Given this list of marker genes ZNHIT1 (NCBI Gene Id 10467), YTHDF1, PRPF38A, SSBP3 (NCBI Gene Id 55126), IL4I1, CAPN8, SIPA1L2, PRPF40A, RIN2, ACVR1, MPP4, CCR8, PBDC1, RUFY3, ARL4A, GOLGA3, TREH, COX17, SLFN12, TMEM168, MRPS7, PAXBP1 (NCBI Gene Id 94104), CDK2AP1, RILPL2, TRAPPC5, EVC, RHBDF1, ABCF1, ATM, SAV1, COX18, SLC28A2, CRKL, RAB22A, CCL7, LY75, PIP4K2B, CCL13, ATF3, ITK, STXBP3, IFIH1, HLA-B, FSCN1, ZMYND11, RFK, FABP4, SOCS6, APOBEC1, PLGRKT (plasminogen receptor with a C-terminal lysine), CD86, SIX5, SFRP1, MBD2 (NCBI Gene Id 8932), WASHC2A, ODC1, HNRNPLL, RTP4, NT5C3A, PLSCR1, DUSP2, CD244, MMS22L, AKAP7, SFXN2, NUB1, GTPBP2, AFTPH, CEPT1, TNFSF9 (TNF superfamily member 9), RIPPLY3, AKR1A1, KPNA3, TOMM70, EVI2A, FRAT2, NMD3, TMEM54, KDM5C, CAMLG, MED1, FKBP7, BRDT, SLC25A20, RPS27, CCNJ, NUS1, CPSF2, CDKN2C, NAT1, ARID2, SPTLC2, HERC2, CPTP, RHOH, CTSG, UBE2R2, SLC6A12, SOCS7, NMNAT1, PADI3, LAD1, TBC1D13, GRIN1, CHRNA5, MRPS6 (mitochondrial ribosomal protein S6), CHST4, B4GALT4, ANKRD24, TMCO3 (transmembrane and coiled-coil domains 3), AP3D1, IQGAP3, HINFP, CCDC102A, TIMELESS, SERPINE1, MUSTN1, CDC42EP3, KDR, POLR1C, ISG20, UBE2D2, TMEM140, ZNF428, MTFP1, HHEX, NRROS, WTAP, INTS9, SLIRP, UFM1, EPRS1, NTM, EBI3, SAP30, EPS8L3, SLC30A1, TANC1, NUP50, GIPC2, CCNB1IP1, RRAGD, RUNX2, PLA2G4F, CASP7, DTNB, NDE1, DUSP14, ALPG, CD72, CCRL2, RARS1, RPP21, TIMP2, MITD1, CYSRT1, PRAP1, DPP3, PDZK1, NFKBIL1, TPBG, ORM1, CR1L, HTRA1, BLMH, PPP3R1, RAB9A, LIN9, CSTF3, RGS1, NOTCH2, TOR3A, CASP4, PLEK, TNFSF4, OGFR, CD276, PTBP1, TPST2, CAP1, HOXA3, TMPO, TRPM5, BATF2, EPSTI1, MMP13, PLCL2, KCTD4, SMU1, RMDN3, SRSF3, AZI2, GABRG1, TNFSF10, CYP2C18, TMEM209, BLNK, FBXL3, IER5, CRYBA1, here is a description of the gene set: studied in species Homo sapiens from publication Amit I, Garber M, Chevrier N, Leite AP, Donner Y, Eisenhaure T, Guttman M, Grenier JK, Li W, Zuk O, Schubert LA, Birditt B, Shay T, Goren A, Zhang X, Smith Z, Deering R, McDonald RC, Cabili M, Bernstein BE, Rinn JL, Meissner A, Root DE, Hacohen N, Regev A (PMID 19729616) Human Gene Set: GSE17721_CPG_VS_GARDIQUIMOD_4H_BMDC_UP Genes up-regulated in comparison of dendritic cells (DC) stimulated with CpG DNA (TLR9 agonist) at 4 h versus DC cells stimulated with Gardiquimod (TLR7 agonist) at 4 h. mouse primary BMDCs were stimulated with tlr ligands and gene expression changes were profiled on Affymetrix arrays